Given this list of marker genes S100A8, S100A7, LTF, S100A9, S100A7A, LCN2, here is a description of the gene set: Human Gene Set: REACTOME_METAL_SEQUESTRATION_BY_ANTIMICROBIAL_PROTEINS studied in species Homo sapiens Metal sequestration by antimicrobial proteins